The following is a description of a gene set: studied in species Mus musculus Mouse Gene Set: chr19D2, and this is the list of marker genes: D730002M21Rik, Pdcd4 (NCBI Gene Id 28204), 4833407H14Rik, Eno4, Mirt1, Rpl31-ps18, Gm36339, Acsl5, Habp2, Afap1l2, Dusp5, 4930484I04Rik, Gm50287, Mir6715, Mxi1, 1700001K23Rik, B230217O12Rik, Nhlrc2, 1810007D17Rik, Rbm20, Gucy2g, Gm17197, Spmip5, Gm31356, Gm9618, Smndc1, 8030456M14Rik, Ppnr, Vwa2, AA387883, Gm32932, Hspa12a (NCBI Gene Id 73442), Ccdc186, Gm32441, Gpam, Bbip1, Gm22271, Gm30381, 6720468P15Rik (RIKEN cDNA 6720468P15 gene), Plekhs1, Gm50270, Gfra1, Pnlip, Nutf2-ps1, Casp7, Atrnl1, Xpnpep1, Shoc2, Ins1, Mir5623, Adra2a (NCBI Gene Id 11551), Pnliprp2, Adrb1 (NCBI Gene Id 11554), Fhip2a (NCBI Gene Id 226252), 1810018F18Rik, 4930449E18Rik, Tdrd1, Trub1, Mif-ps9, Smc3, Gm16299, Pnliprp1, 1810035K13Rik, Ccdc172, Tcf7l2, Gm32492, Vti1a, 1700054A03Rik, Gm30541, Mir3086, Gm16277, Gm31912, Zdhhc6, Mir6407, Ablim1, Dclre1a, Nrap, Tectb, Add3